Given this list of marker genes CD22, RFK (riboflavin kinase), ARRB1, IGLC7, ANXA7, IL10RA, MTPN, SLC25A53, C9orf85, GLCE, ZNF385A, PLCG2, TMEM176A, INPPL1, DNAJB9, ADAM10, SNX2, MS4A1, SUCLG2 (NCBI Gene Id 8801), PSEN2, CD40, MGAT1, TK2, MCL1, NID1, ROCK1, UBA3, CYRIB, ITFG1, CDC42SE2, SLC44A1, MAN2A1, PKIG, SPG21, RPN1, EEA1, CD38, SYPL1, ALG2, CHD1, LMO7, PLAUR, SRGN, IVNS1ABP, SLC4A7, SPINK4, GNS, QRSL1, PSAP, HCK, AP1G1, VAMP4, STX7, OAT, CTSH, CMTR1, BTK, CIITA, ANXA2, APOBEC1, PSMD14, TCF4, SAFB, MYCBP2, STK25, TXNDC16, MYO5A, FAM91A1, ACADL, MYADM, ING4, TLR7, IREB2, TFAM, UBE2D3, MGST1, ENTPD1, CEP89, SNX5, CD79B, EPB41L2, MAPK12, C1orf43, RSU1, C6orf89, NDST1, EIF2AK4, ETS1, SLC25A15, NUCB2, SBF2, ERP29, CLTC, MDFIC, UBL3, HSPA4, PSPC1, RALGPS2, EPCAM, WBP4, TUBB6, DENND5A, CD83, ZC3H12C, RAB31, KLC1, GGA2, LIMD1, SLC7A7, PLEKHB2, RAB24, CTSC, RAP1A, SPIB (Spi-B transcription factor), INPP5A, PRKCD, LUC7L, CCNG1, TOR3A, KLF4, GOSR2, IST1, EVI2A, FCRLA, UIMC1, FICD, TMED1, S100A4, RNF11, PBX3 (NCBI Gene Id 5090), HLA-DOB, ASNSD1, PPID, CRIP1, CD19, ADM, GAS7, CYFIP1, FNDC3A, HLA-DQA1, PLP2, IMMP1L, AHNAK, ZSCAN26, MAP3K8, PLSCR1, PTS (NCBI Gene Id 5805), UPF3B, SYK, HSD17B11, RHOQ, CD9, LMO2, EPS15, DRAM2, UBE2G1, GNG10, POU2AF1, ARIH1, CR2, TIPARP, CXCR5, PLAC8, LYL1, STARD10, CD74, RPS6, EI24, PDE8A (NCBI Gene Id 5151), LYN, BLNK, YIPF1, MPEG1 (NCBI Gene Id 219972), PLBD1, GANAB, PISD, TEP1, CCDC28B, VPS4B, ALOX15, SNX10, PCSK5, ANXA1 (annexin A1), DIDO1, TRNT1, SACM1L, RNFT1, EPS8, TNPO1, TULP4, MIF4GD, SSPN (NCBI Gene Id 8082, sarcospan), GPR137B, STXBP3, LY6D, NAPSA, RAB14, BLK, RAB10, CCDC90B, here is a description of the gene set: Genes down-regulated in CD8 T cells: KLRB1 int versus KLRB1-. studied in species Homo sapiens Human Gene Set: GSE33425_CD161_INT_VS_NEG_CD8_TCELL_DN from publication Walker LJ, Kang YH, Smith MO, Tharmalingham H, Ramamurthy N, Fleming VM, Sahgal N, Leslie A, Oo Y, Geremia A, Scriba TJ, Hanekom WA, Lauer GM, Lantz O, Adams DH, Powrie F, Barnes E, Klenerman P (PMID 22086415) This SuperSeries is composed of the SubSeries listed below.